Given this list of marker genes GAS2L1 (growth arrest specific 2 like 1), PRKAR1A, ARPC3, CLN3, EPHA3, SPTA1, PEAK3, CXCL12, PYCARD, PDLIM3, CRYAA, NISCH, BLOC1S6, CDC42EP5, TRIM27, WIPF3, TNIK, EEF2K, EPHA1, ARHGEF17, SDCBP, PDE4D, KANK4, S1PR2, WDR1, SNTA1, EPB41, MIR20A, TAC1, EVL, TRPV3, MYH10, NUP155, PAK2, LMOD1, TENM1, ARHGEF26, ITGB1BP1, ARPC2, HIP1R, MYOM1, MYO7A, FMNL3, SCN1B, SHROOM3, TMSB4Y, CAPZA2, EPB41L4A, LIMD2, GHSR, WASHC5 (NCBI Gene Id 9897), AVIL, PLS1, TJP1 (tight junction protein 1), WHAMM, SPECC1L, ARHGEF15, TMOD4 (tropomodulin 4), CSRP2, ABRACL, TMSB4X, CAPZA3, ABI3, ARPC5, NCK2, ADCY10, ZYX, AMOT, ALMS1, TNNT2, SRC, FGF10, DAPK3, RND2, PTGER4, ARFIP2, MIR149, BCAS3, MYO1A, KASH5, SHTN1 (NCBI Gene Id 57698), ALKBH4, ARHGEF2, PPP1R9A, FGD6, SHROOM1, MYOZ1, NOS1, CORO1C, SH3BP1, DSG2, PTK7, DNM2 (NCBI Gene Id 338330), DVL3, CASQ1, COBL, MYH2, MYPN, KRT19, PIP5K1C, MYO15A, SPTBN2, TWF2 (twinfilin actin binding protein 2), ABI2, ALDOA, ACTL8, ELMO1, TMEFF2, SVIL, INPPL1, ITGB3, LPAR1, ARPC1B, SHANK1, WASHC2C, NUAK2, CCN2, ACTN2, MYL11, NAA20, SPTBN5, RFLNA (refilin A), EPB41L1, BBS4, CSRP1, BCL2, LMOD2, MYBPC1, MYO18B, ADD3, F11R, NF1, PLEKHH2, GBA2, RHPN2, LIMK2, CD47, KPTN, ADRA2A, ESAM, RHOQ, FRMD3, SIGLEC15, FAT1, NOS1AP, MIR214, FGF12, PICK1, CAV1, HIP1, HDAC6, CYTH2, SH3D21, IQGAP3, MYBPH, SMIM22 (NCBI Gene Id 440335), MYH9, HSP90B1, RHOBTB1, MKKS, MAD2L2, BRAF, SPTBN4, CLASP2, PKP3, TLN2, JMY, EPS8, SIPA1L1, TLN1, TMSB15A, DIXDC1, KLHL1, PDLIM7, LIMA1, MYLK2, STC1, ECT2, SHROOM2, WASH3P, RHOG, PFN2, GRB2, CFLAR, FAM171A1, RAC2, APOA1, CDC42, MAGEL2, ARAP2, KCNA5 (potassium voltage-gated channel subfamily A member 5), MYOM2, MYO19, GHRL, CYFIP1, FZD10, MYBPC3, MIR133A1 (NCBI Gene Id 406922), RHOF, RYR2, RAN, PLA2G1B, MYO7B, MICAL2, SPIRE2, CTNNA2, PIP5K1A, PHACTR3, ARHGEF5, OR2A4, RAP1GDS1, TAOK2, KRAS (KRAS proto-oncogene, GTPase), RHOBTB2, HMCN1, SCN9A, CLRN1, TMOD3, ARHGEF11, ARFGEF1, BCAR1, PRKCE, DBN1, RHOD, NAA80, CORO2B, ARHGAP25, SORBS3, GJA1, GMFG, KANK3, TRIP10, SCN3B, PDPK1, SHANK3, PPP1R9B, FLII (FLII actin remodeling protein), MYH11, WASF1, KANK1, SH3KBP1, PCLO, ARRB1, RNH1, ABCC9, ACTA2, ANTXR1, SSH3, CAP1 (NCBI Gene Id 10487), CGNL1, EPB41L4B, ELN, PDXP, MYO1E (NCBI Gene Id 4643), FSCN1, C15orf62, PLS3, CLASP1, S1PR1, TPM4, C9orf72, FAM107A, GAS2, DTNBP1, PRKCI, PRKCD, ABITRAM, SRF, WASHC4, ARPC4, PTPN1, MYH14, DPYSL3, MET, PHACTR4, AIF1, NEDD4L, MYO1G, SUN2, CARMIL3, CNN2, TTC17, MYBPC2, NF2, TCAP, ACTR2, GAS2L2, FMNL1, DSTN, MICALL2, ASAP3, PKP2, ITGB5, AKAP13, CLDN19, PDCD10, RND1 (NCBI Gene Id 27289), ABI1, CUL3, ANG, SETD3, TRPM7, MYO18A, FMN1, DIAPH2, ANKRD1, PACSIN1, C10orf71, COTL1 (coactosin like F-actin binding protein 1), KANK2, IQSEC1, TACR1, PARVG, CSF1R, CDC42BPG, KCNE2, AMOTL2, PDLIM1, CDC42EP4, CDC42BPA, ITPKA, RHOB, CNN1, NPHS2, SFRP1, WASHC1, WNT4, ATP1A2, ACTBL2, PPFIA1, STARD8, DSP, NPHS1, PRICKLE4, CACNA1C, EHD2, MIR335, MYO3A, TMSB15C, CNN3, TAGLN2, WASH6P, TAOK1, LUZP1, BCL6, CYFIP2, MYOZ2, WASHC2A, POTEI, TRIM32, SPIRE1, ADD2, RACGAP1, WASL, MIR448, SCN3A, CACNA2D1, ACTN1 (actinin alpha 1), DNAI3, TNFAIP1, KCNE5, AMOTL1, ABL2, KCNQ1, ARHGEF18, BST2, MYO1D, SWAP70, FGD3, KCNE3, ARPC1A, AP1AR, CASQ2, LIMCH1, GJA5, ANKRD23, TTC8, OBSCN, POTEE, TNXB, PIK3R2, SEMA5A, HAX1 (HCLS1 associated protein X-1), PLEKHG2, FARP1, NCKAP1, FHOD3, SMAD3, KLHL41, MYO1B, CTTN, GJC1, PREX1, DOCK2, RTKN, EPHA5, SORBS1, ARFIP1, CACNA1G, GAS2L3, MIR21, XIRP1, ENAH, TGFB1, ANXA1, FGF13, IQSEC2 (NCBI Gene Id 4382), ALOX15, KCNE1, MIR1-1, PIK3CA, ARHGAP18, OBSL1, TNNT3, ACTC1, ATP2A1, CDK10, ARPC5L, CTNNA3, EPB41L5, SCN4A, ZBED3, DSG3, TPM2, ACAP2 (ArfGAP with coiled-coil, ankyrin repeat and PH domains 2), FRMD7, ACTA1, CARMIL1, ARHGEF10L, MYH7, SH3GL2, VIL1, SLC4A2 (solute carrier family 4 member 2), SEPTIN9, ESPN, CDC42EP3, KCNN2, DNAJB6, CORO7, CXCL1 (C-X-C motif chemokine ligand 1), FGD5, PDLIM2, KCNH2, MYOM3 (myomesin 3), EZR, ACTR3, ASB2, SELE, FSCN2, CCL21, CD2AP, MYADM, ARHGAP26, FERMT2, BIN3, MYL9 (NCBI Gene Id 10398), AUTS2, KHDC3L, MICAL1, FGD4, STAU2, SCN1A, DLG1, DIAPH3, SH2B2, PLEC, SCN4B, RGS4, RHOC, SCN2B, MYH4, ABRA, KCNC3, FRMD6, KCNJ3, SYNPO2L, PHACTR1, KCNE4, SHROOM4, PFN1, MYO1F, NGEF, THSD7A, FLNB, NRP1, CSRP3, INSRR, CORO1B, TWF1, ARHGAP17, MYL1, MRAS, CARMIL2, ROCK2, TYROBP, MIR328, INF2, CFL1, MRTFA, MTSS1, MYOC, SPTB, MYO5A, PGM5, FGF7, CRK, NCK1, JAM3, SYNPO2, EFNA5, RICTOR, GPM6B, CAMK2D, KIT, F2RL1, PHPT1, QKI, ROCK1 (NCBI Gene Id 6093), PIK3R1, STRIP1, MYL6, CELSR1, SCN11A, RHOJ, RHOA, LLGL1, CALR (calreticulin), CAV3, MSRB1, MYH6, PALLD, FGD2, CDK5, DIAPH1, MARCKSL1, TMOD1, ESPNL, TNNT1, CYRIA, PRKN, PAK1, LMOD3, GDPD2, SHC1, ARHGAP35, PACSIN2, CIT, PXN (paxillin), HCN4, GMFB, GPD1L, FNBP1L, CCL11, POTEF, KBTBD13, ATP2C1, SLIT2, BRK1, SMAD4, NEDD9, TTN (titin), TRPM2, ACTN4, VASP, MYH3, AQP2, PALM2AKAP2, ACTN3, CLDN3, ARAP1, CPNE6, HRG, FMN2, BRSK2 (BR serine/threonine kinase 2), MYO3B, EPDR1, AKAP11, NEB, PDCD6IP, THSD7B, NKX2-5, STARD13, CAPN10, HCLS1, SIX4, S100A10, ATP2A2, CAPN3, CAVIN3, CRACD, GPR65, AKAP9, ARHGEF16, PPM1E, RALA, SERPINF2, RHOU, ITGB1, AIF1L, TGFBR1, POTEJ, FHDC1, CAPZA1, AQP5-AS1, CFL2, TBCK, ODAM, CCR7, MYO5C, KCNJ2, ARPIN, PRKG1, TNNI3 (troponin I3, cardiac type), FER, PDCL3, PLEK2, FLNC, XIRP2, ELMO3, EMP2 (NCBI Gene Id 2013), TESK1 (testis associated actin remodelling kinase 1), NHERF1, RANGRF, SCN5A, CDC42BPB, JUP, SCIN, PLN, ERMN, SLC9A1, SYNPO, GSN, LCP1, RNF207, ACTG1, EDN1, TMSB15B, SCN2A, PARVB (parvin beta), MARCKS, TAGLN3, PDGFRA, ABL1, LATS1, PAWR, ARF1, FCHSD1, DAAM2, POF1B, OAZ3, DMTN, DVL2, SRGAP2, SNX9, RDX (NCBI Gene Id 5962), KCTD13, VILL, MICAL3, ATP1A1, CAPZB, ARHGAP12, LLGL2, SYNE2, CORO1A, KLHL17, TLE6, CCL24, PARVA, POTEKP, PDLIM4, RND3, SPATC1L, MYO1C, NCKAP1L, ARF6, MKLN1, MIR138-1, ARHGAP44, SCN10A, MTPN, TMOD2, TACSTD2, SCN8A, FMNL2 (formin like 2), SDC4, CYRIB, MYH7B, RFLNB, SGCD, HCK, MYO6, WASHC3, BAIAP2L2, SPTAN1, MYLK3, RAP2A, DLC1, PAK3, INPP5K, RHPN1, MYH8, PHLDB2, FARP2, TESK2, ARHGEF10, RHPN2P1, ADD1, FLNA, ELMO2, PAFAH1B1, TGFB2, MSRB2, DSC2, CDC42EP1, MIR143, LRP1, ARHGEF19, DAAM1, TRPM4, PLEK (pleckstrin), LDB3, TRIOBP, CDK5R1, RAPGEF3, OOEP, CACNB2 (NCBI Gene Id 783), RASA1, ADPRHL1, AQP1, MYL2, EPB41L3, GATA4, ARHGAP28, BCR, WAS, SRCIN1, PROX1, SUMO1, MLST8, CXADR, SYDE1, IQGAP2, PFN3, KIRREL1, BST1, CORO6, PTK2B (NCBI Gene Id 5748), RGCC, PDGFA, DBNL, PDE4B, ACTB, ARHGAP40, RUFY3, MEF2A, CALD1, FOXJ1, PDLIM5, MYO5B (myosin VB), IQSEC3, MYO9B, WASF2, CAPG, NPHP1, USH1C, SAMD14, CACNA1D, SPTBN1, CX3CL1, FCHSD2, NPHP4, CSF3, VPS4A, CCDC88C, PHACTR2, ATXN3, CATIP, MIR145, KCNJ5, FHL3 (NCBI Gene Id 2275), ANLN, KCNJ8, RAC3, NEBL, IQGAP1, MTOR, WIPF1 (NCBI Gene Id 7456), BMP10, RHOV, SSH1, ARAP3, MYO1H, PDPN, PRKD1, EPB41L2, CDC42EP2, PPM1F, SCN7A, PDGFRB, BAG4, RHOH, LIMK1, STRIT1, ANK2, TNNC1, SPECC1, FGD1, FSCN3, AGAP2, KCND3, TPM3, BIN1, MINK1, BAIAP2, ZEB2, STMN1, VANGL2, RAB13 (NCBI Gene Id 89672), SRI, FRMD5, NRAP, HRAS, TPM1, TGFB3, FHOD1, CCDC88A, SSH2, JAK2, MYL6B, ARHGAP6, CCL26, TRPV4, TSC1, GRHL3, OPHN1 (NCBI Gene Id 4983), WASF3, ADORA1, RAC1, TMSB10, BAIAP2L1, CAP2, NLRP5 (NCBI Gene Id 126206), here is a description of the gene set: Any cellular process that depends upon or alters the actin cytoskeleton, that part of the cytoskeleton comprising actin filaments and their associated proteins. Human Gene Set: GOBP_ACTIN_FILAMENT_BASED_PROCESS species: Homo sapiens